Given this list of marker genes B4GALT7, MCOLN1, SKI, CANT1, AP4B1, AP4S1, PDGFRB, WASF1, HRAS (NCBI Gene Id 338029), CFL2, TRIP11 (NCBI Gene Id 9321), LMX1B (LIM homeobox transcription factor 1 beta), AP4M1, MAN2C1, COMP, MEFV, CHST3, ELN, SH3PXD2B, ALDH18A1, ANO5, ORC1 (NCBI Gene Id 4998), KRAS, COL1A2, GRIA3, CTDP1, FGFR3, TNFRSF1A, CDT1, COL5A1, PTEN, FBLN5, PRR12, FBN1 (fibrillin 1), AP4E1 (NCBI Gene Id 23431, adaptor related protein complex 4 subunit epsilon 1), XYLT1, NRAS, CSGALNACT1, FGD1, ASCC3, SLC6A9, here is a description of the gene set: Human Gene Set: HP_HYPEREXTENSIBILITY_OF_THE_KNEE species: Homo sapiens The ability of the knee joint to extend beyond its normal range of motion (the lower leg is moved beyond a straight position with respect to the thigh). Hyperextensibility of the knee